Given this list of marker genes SOD1, SSH1, BSG, ASPH, ADIPOQ, P2RY4, AQP1, RAP1A, P2RY1, KCNE1, VGF, SLC8A3, HCN4, OXT (NCBI Gene Id 5020), PKD2, AKAP7, P2RY12, TRPM4, P2RY6, TIFAB, SLC5A5, RELA, DMTN, STC1, RAP1BL, INPP5K, PNPT1, SCX, P2RY11, WT1, LPAR1, ABCC9, KCNQ1, AHR, TAF1, NPR2, DNTT, RAP1B, PIK3CG, P2RY2, GPD1, ZFP36L1, DGKQ, KCNJ8, CRTC1, CFTR, ITPR2, RYR3, CDO1, WNT10B, TRPC3, DUOX1, TOP1, MMP19, AANAT, EEF2K, ASS1, SLC6A4, HCN3, THBD, PDE3A, P2RX5, TYR, SLC26A6, PER1, CRHBP, HCN2, CIB2, AQP9, P2RX2, CNGA3, HMGCS2, NT5E (NCBI Gene Id 4907), AREG, SRD5A1, PDXP, ALAS1, GATA1, EZR, KCNJ11, DUOX2, DUSP1, STAT1, REN, FOSB, ENPP1, CRTC3, PENK, ATP5PO, APP, COL1A1, TLR7, IL1B, P2RX3, PDE4D, CITED1, AKAP9, PKLR, P2RX6, KDM1A, HSP90B1, SLC6A3, AKAP6, FOS, RAPGEF3, CPS1, PANX1, P2RX1, HCN1, TRPV1, GUCD1, ERRFI1, NDUFS4, AQP8, BIRC2, FBP1, SREBF1, CARM1, PDE2A, RAPGEF2, INHBB, TOP2B (NCBI Gene Id 7155), P2RX4, P2RX7, RAPGEF1, SLC26A3, IGFBP5, FDX1, CRTC2, here is a description of the gene set: species: Homo sapiens Any process that results in a change in state or activity of a cell or an organism (in terms of movement, secretion, enzyme production, gene expression, etc.) as a result of an organophosphorus stimulus. Organophosphorus is a compound containing phosphorus bound to an organic molecule; several organophosphorus compounds are used as insecticides, and they are highly toxic cholinesterase inhibitors. Human Gene Set: GOBP_RESPONSE_TO_ORGANOPHOSPHORUS